Given this list of marker genes CHMP4C (charged multivesicular body protein 4C), VPS39, CHMP7, LRRK2, CHMP4A, CHMP4B, VPS4A, CHMP4BP1, CHMP6, C9orf72, VPS35, SNAPIN, CHMP3, CHMP5 (charged multivesicular body protein 5), VPS41, ARL8B, PLEKHM1, VPS4B (NCBI Gene Id 9525), CHMP1A, CHMP1B, CHMP2A, CHMP2B, here is a description of the gene set: The directed movement of substances from late endosome to lysosome. studied in species Homo sapiens Human Gene Set: GOBP_LATE_ENDOSOME_TO_LYSOSOME_TRANSPORT